Given this list of marker genes NCKAP1, SGK3, WWC3, BCAT1, ETNK1, KLF4, SOAT1, NAB1, IFT25, ANG, SLC35B4, PCK2, DENND5B, PHGDH, KCNS3, GPX8, DDHD2, DSG2 (desmoglein 2), SFXN1, ATP9B, GALNT4, HSPA1A, CCN3, VEPH1, NECTIN2, FRK, LIPA, ASNS, EPS15, SKP2, OSTM1, TRIP12, ARRB1, LINC00294, CEACAM6, TRAK1, SGMS2, GPX2, STC2, CCL2, ASPH, TMTC2, S100P, TRIM37, PRKAA1, APOH, FAM3C, SORL1, PSAT1, SLC3A2, AKR1C3, PGM2L1, CBS, FZD6, HSPA1B, G3BP1, CREB3L2, PEX19, RETREG1 (reticulophagy regulator 1), DOCK11, LEPR, SLC22A18, SLC7A5 (solute carrier family 7 member 5), AGR2, ANK2, RAP1GAP, AP5M1, POF1B, SLC1A4, AKT3, RHOBTB1, PACSIN2, GNPTAB, NEBL, INSL4, TAF13, CDK19, PER2, NEURL1B, AKR1C1, CBX1, ST8SIA4, DICER1, KIAA0232, LIN7A, SUCLG2, DDC, TOMM20, CDS1, PRR15, SEC24D, LMNB1, VPS36, ARPC1A, OPN3, RPS6KA3, KPNA1, ATF4, here is a description of the gene set: Genes down-regulated in A549 cells (lung cancer) after knockdown of ATF4 by RNAi. Human Gene Set: IGARASHI_ATF4_TARGETS_DN studied in species Homo sapiens The mechanisms underlying cellular drug resistance have been extensively studied, but little is known about its regulation. We have previously reported that activating transcription factor 4 (ATF4) is upregulated in cisplatin-resistant cells and plays a role in cisplatin resistance. Here, we find out a novel relationship between the circadian transcription factor Clock and drug resistance. Clock drives the periodical expression of many genes that regulate hormone release, cell division, sleep-awake cycle and tumor growth. We demonstrate that ATF4 is a direct target of Clock, and that Clock is overexpressed in cisplatin-resistant cells. Furthermore, Clock expression significantly correlates with cisplatin sensitivity, and that the downregulation of either Clock or ATF4 confers sensitivity of A549 cells to cisplatin and etoposide. Notably, ATF4-overexpressing cells show multidrug resistance and marked elevation of intracellular glutathione. The microarray study reveals that genes for glutathione metabolism are generally downregulated by the knockdown of ATF4 expression. These results suggest that the Clock and ATF4 transcription system might play an important role in multidrug resistance through glutathione-dependent redox system, and also indicate that physiological potentials of Clock-controlled redox system might be important to better understand the oxidative stress-associated disorders including cancer and systemic chronotherapy. from publication Igarashi T, Izumi H, Uchiumi T, Nishio K, Arao T, Tanabe M, Uramoto H, Sugio K, Yasumoto K, Sasaguri Y, Wang KY, Otsuji Y, Kohno K (PMID 17297441)